Given this list of marker genes S1pr5, Pik3cg, S1pr2, Mfsd2b, S1pr1, Akt1, Sphk1, S1pr3, Spns2, Gpr6, Pik3cb, Sphk2, Rac1 (Rac family small GTPase 1), Ezr, S1pr4, here is a description of the gene set: A G protein-coupled receptor signaling pathway initiated by sphingosine-1-phosphate binding to its receptor on the surface of a cell, and ending with the regulation of a downstream cellular process, e.g. transcription. studied in species Mus musculus Mouse Gene Set: GOBP_SPHINGOSINE_1_PHOSPHATE_RECEPTOR_SIGNALING_PATHWAY